Given this list of marker genes IDO2, GPA33, CYTH1, HPD, BTG3, DNAJC5G, AIM2, SNIP1, AGK, RAP2C, TNFRSF10A, TIA1, CRLF2, CAPSL, GIMAP4, HCG4, GRB10, LINC01931, PDIA3, PLCL1, POPDC2, RNF19A, MAMLD1, PDE4DIP, GUCY1B1, LINC00528, ALOX15B, TMOD2, ICAM2, JAK2, TARP, PRRG4, TTC39B, MIR155HG, KIAA0040, LAD1, SLC25A37, MAS1, TAB2, BAALC, TNFRSF9, DCUN1D3, RGS20, MGC16275, FEM1C, GYPC, PCDHGC5, SNX10, FAM66D (family with sequence similarity 66 member D), IFNL1, TSPY1, IFI35, VEZF1, EMP1, BTNL8, NRP2, TSC22D2, UNC13D, RAET1E, ENTHD1, OSM, PMAIP1, MICALL1, GBP1, NBL1, FOXF1, PPBP, MSANTD1, MCUB, SPARC, CPEB2, SLC2A13 (NCBI Gene Id 114134), SNX11, GBE1, SIAH2, FNDC3A (fibronectin type III domain containing 3A), GNPTAB, CTHRC1, HLA-DOB, HCAR3, MAP4K4, TENT2, CER1, ABCB5, HRH1, C1QTNF1, KLF4, IL12RB1, STK4, NEMP1, GALM, SSR1, RPS6KC1, LY86, BIRC3, ESYT2, NFE2, C17orf58, CLINT1, SCG3, BHLHE40, SPRED2, CRISPLD2, IL15, CCKAR, PELI1, TNFSF4, GUCY1A1 (NCBI Gene Id 2982), UNC5C, CPNE8, AK8, CCNA1, CFB, UPB1, SLC6A14, LINC01356, PEAK1, RBM46, UBE2E1, RAB9A, TCF7L1, SLCO3A1, LAMP3, STX5, OAS2, PLS3, NPTX2, PGAP1, KDM6A, GNS, SQOR (NCBI Gene Id 58472), ZBTB32, CAPN2, STOM, PXYLP1, MVP, EPB41L3, PLEKHF2, MFSD12, SAR1A, SERPINB7, SPAG9, STRIP2 (striatin interacting protein 2), TTC6, TFEC, WASL, UBE2Z, ERLEC1P1, NBN, DNAI3, ABCG1, TPPP, SGMS1, ERO1A, C1orf226, MACROH2A2, EZH2, RARG, SDC4, C4orf33, LATS2, TCN2, LYSMD2, COBL, SRSF4, DDX60L, DPPA3 (developmental pluripotency associated 3), MGLL, MTMR4, MECP2, MAGT1, PLD1, CD80, GJA4, LINC00158, CFAP70, PATL2, PRSS23, GBP5, N4BP1, SLC38A5, DDX60, RAB11FIP1, NTN1, PNRC1, TMEM50A, PMCHL1, RUFY3, POU6F2, ERP44, here is a description of the gene set: Human Gene Set: GSE2706_R848_VS_LPS_8H_STIM_DC_DN Toll like receptors (TLRs) sense microbial products and initiate adaptive immune responses by activating dendritic cells (DCs). Since pathogens may contain several agonists we asked whether different TLRs may synergize in DC activation. We report that in human and mouse DC TLR3 or TLR4 potently synergize with TLR7, TLR8 or TLR9 in the induction of selected cytokine genes. Upon synergistic stimulation, IL-12, IL-23 and Delta-4 are induced at levels 50-100 fold higher than those induced by optimal concentrations of single agonists, leading to enhanced and sustained TH1 polarizing capacity. Using microarray analysis we show that only 1.5% of the transcripts induced by single TLR agonists are synergistically regulated by combinations of TLR4 and TLR8 agonists. These results identify a combinatorial code by which DCs discriminate pathogens and provide (suggest) a rationale to design adjuvants for TH1 responses. Series_overall_design: 3 untreated, 3 treated with LPS at 2h, 3 treated with LPS at 8h, 3 treated with R848 at 2h, 3 treated with R848 at 8h, 3 treated with LPS + R848 at 2h, 3 treated with LPS + R848 at 8h studied in species Homo sapiens from publication Napolitani G, Rinaldi A, Bertoni F, Sallusto F, Lanzavecchia A (PMID 15995707) Genes down-regulated in comparison of dendritic cells (DC) stimulated with R848 at 8 h versus DCs stimulated with LPS (TLR4 agonist) for 8 h.